The following is a description of a gene set: The directed movement of sodium ions (Na+) into, out of or within a cell, or between cells, by means of some agent such as a transporter or pore. Human Gene Set: GOBP_SODIUM_ION_TRANSPORT studied in species Homo sapiens, and this is the list of marker genes: ASIC1, SLC10A2 (solute carrier family 10 member 2), SLC6A16, MIR192, SLC6A19, FXYD2, ATP4A, SCNN1B, SLC34A1, CNGB1 (NCBI Gene Id 1258), HCN2, NKAIN3, SLC22A4, CHP1, SLC41A1, SLC6A20, TPCN2, SLC5A5, SLC23A1, SLC6A7, SLC5A1, SLC6A4, MAGED2, SLC17A4, SLC6A14, SLC34A2, PON3, SLC24A2, EDNRA, TPCN1, SLC17A3, SLC6A1, SLC20A2, SLC38A3, NKX2-5, SCN3B, CNNM4, SLC6A18, SLC6A11, NEDD4, ATP1B4, GPD1L (glycerol-3-phosphate dehydrogenase 1 like), MCOLN3, SLC28A3, WNK1, CAV3, SCN4B, SLC9A6, COMMD3, DMPK, SCN10A, YWHAH, GUCA2B, SLC38A11, FXYD4, SLC5A4, PKD2 (NCBI Gene Id 5311), SLC12A1, MFSD4B, ASIC3, SCNN1D, TRPM2, SLC9A2, SLC9B1, SLC4A5, PKD2L1, SLC6A2, SLC5A6, SLC22A5, ATP4B, GRIN1, SCN11A, SLC9A3, SLMAP (NCBI Gene Id 7871), SLC6A12, AGT, MIR24-1, NPPA, SCN9A, SLC6A17, SLC5A2, SLC12A2, SLC17A6, NHERF1, TGFB1, FXYD3, CNKSR3, SLC38A5, SLC38A1, EDNRB, SLC17A1, ATP1A3, CATSPER4, SNTA1, SLC6A13, SLC4A4, MIR448, SLC17A8, CLCNKB, TESC, SLC9C1, SLC9C2, SCN1A, SCN5A, ATP1B3, NKAIN2, SLC5A8, STK39, NEDD4L, KCNK9, SLC23A2, SLC4A9, SLC6A6, CAMK2D, SLC10A5, SLC5A11, SLC13A2, ASIC2, SLC34A3, ATP1B1 (NCBI Gene Id 481), ADRB2, SLC4A10, SLC38A4, UMOD, SLC9A5, SLC17A7, SERPINE2, SLC4A7, ASIC5, SLC8A2, FGF12, SPTBN4, OXSR1, NALCN, KLHL3, TRPM4, FXYD6P3, SLC10A1, SLC12A3, SLC24A3, FXYD7, P2RX4, SLC13A3, SLC5A12, SLC9A9, HCN3, NOS1, SIK1, PKP2, SLC9A8, SCN3A, SLC17A2, CNGA4 (cyclic nucleotide gated channel subunit alpha 4), SLC41A3, AHCYL1, HCN1, SCN4A, MLLT6, SLC10A7, WNK4, CATSPER3, ATP6V1B1, MCOLN1, NDUFA9, ATP12A, SCN2B, GRIN2A, SCN7A, SLC6A9, FXYD5, CNGA3, SLC5A3, SLC4A11, SCNN1G, KCNJ1, RANGRF, WNK3, NKAIN1, SLC10A6, SCN1B, SLC24A1, WNK2, ATP2B4, PCSK9, SLC10A4 (NCBI Gene Id 201780), SLC4A8, SLC6A8, NOS3, PTPN3, SLC8B1, AKT1, ATP1A2, SLC8A3, KCNE3, SLC6A5, SLC5A9, FXYD6, SLC9A7, SCN2A, SLC6A3, FGF13, OSR1, ATP1B2, DMD, SLC13A4, SLC38A2, ACTN4, PRKCE, COMMD9, DLG1, SLC13A1, KCNQ1, PER1, SLC5A7, SLC9A1, ATP1A4, BPIFA1, SLC20A1 (NCBI Gene Id 6574), CNGA2, SLC24A5, KCNK3, CNGA1, HCN4, SLC9B2, EDN1, SLC38A7, TRPV3, SLC8A1, KCNK1, SLC13A5, UTRN, SCN8A, SLC6A15, FXYD1, SHROOM2, ANO6, NKAIN4, SLC24A4, SCNN1A, CNTN1, ANK3, SLC9A4, COMMD1, DRD2, ATP1A1, SLC5A10, PRSS8, GRP, SGK1, TRPM5, ASIC4, P2RX7 (NCBI Gene Id 5027, purinergic receptor P2X 7)